Given this list of marker genes SGCB, KLHL31, IFFO2, DDX51, RALGAPA2, SERTAD3, MGAT5, MECP2, FRMPD2, CDK11A, POLG, DHRS9, COG6, PRCP, NR2E1, WNT10B, RPE65, CLCN3, SCN8A, ADGRG4, EYA3, TMEM130, CDH4, SLC2A1, RGS7BP, BRINP2, TMCC1, DPPA5, YARS1, MAP3K4, ATAD2B, RIMBP2, SLC16A6, ETV6, CCL4L2, SRGAP2, HTR1A, CBR1, PLAG1, SEMA4B, PPP2R5D (protein phosphatase 2 regulatory subunit B'delta), FXYD3, AMACR, USP9Y, MMP24, SPDEF, ATOSB, SAPCD1, GUCY1A2, HOXA13, ISLR, ENPEP, FOXG1, DCAF5, ZC3H7B, USP8, TEX261, DYNLL2, DUSP8, ERC1, SNX16, TSPAN1, RC3H1, KDM2A (NCBI Gene Id 22992), DCX, UBE2D3, MRPS10, EIF2AK1, HMGA1, PTGIR, NR5A2, SLC39A1, JMJD6, LRRN3, LY75, GNAZ, TGFBR1, C17orf58, ATRN, SEMA6A, GAL3ST3, SLC35F1, ABL2, BCL2L1, P3R3URF-PIK3R3, RNF170, ZNF213, ZNF717, CHST14, PNISR, PIK3R3, KRT39, TOM1L2, GRK3, PDE1B, MYLK4, NECTIN1, CERS1, ZDHHC16, GFPT2, PGAP2, RPRD1A, TNPO2, PXDN, SDK2, NINJ2, ZNF704, EPN3, here is a description of the gene set: Human Gene Set: MIR6081 from publication Chen Y, Wang X (PMID 31504780) species: Homo sapiens Genes predicted to be targets of miRBase v22 microRNA hsa-miR-6081 in miRDB v6.0 with MirTarget v4 prediction scores > 80 (high confidence targets).